The following is a description of a gene set: Mouse Gene Set: GOBP_PROTEIN_OXIDATION The modification of a protein amino acid by oxidation. studied in species Mus musculus, and this is the list of marker genes: Loxl2, Apoa1, Prdx3, Lox, Gpx1 (NCBI Gene Id 14775), Chchd4, Loxl3, Sumf1, Trabd2b, Naglu, Apoa2